The following is a description of a gene set: A cell migration-dependent mechanism for releasing cellular contents. species: Homo sapiens Human Gene Set: GOBP_MIGRACYTOSIS, and this is the list of marker genes: MYO19, KIF5B, PKD1, DNM1L, EPCIP, TSPAN9